Given this list of marker genes HLCS (holocarboxylase synthetase), ACACB, PCCA, MCCC1, PC, here is a description of the gene set: species: Homo sapiens Binding to biotin (cis-tetrahydro-2-oxothieno(3,4-d)imidazoline-4-valeric acid), the (+) enantiomer of which is very widely distributed in cells and serves as a carrier in a number of enzymatic beta-carboxylation reactions. Human Gene Set: GOMF_BIOTIN_BINDING